Given this list of marker genes IL34, PTK2 (NCBI Gene Id 5747), CSF1R (colony stimulating factor 1 receptor), MAPK1, MIR181B1, IL33, MAPK3, here is a description of the gene set: studied in species Homo sapiens Any process that modulates the frequency, rate or extent of macrophage proliferation. Human Gene Set: GOBP_REGULATION_OF_MACROPHAGE_PROLIFERATION